The following is a description of a gene set: species: Mus musculus Mouse Gene Set: GOBP_VITAMIN_D_BIOSYNTHETIC_PROCESS The chemical reactions and pathways resulting in the formation of vitamin D, any of a group of related, fat-soluble compounds that are derived from delta-5,7 steroids and play a central role in calcium metabolism. Specific forms of vitamin D include calciferol (ergocalciferol; vitamin D2) and cholecalciferol (calciol; vitamin D3)., and this is the list of marker genes: Snai1, Snai2, Gfi1, Nfkb1, Ifng, Cyp27b1, Tnf, Cyp2r1, Cyp24a1, Cyp27a1